The following is a description of a gene set: Human Gene Set: DESCARTES_FETAL_PANCREAS_ACINAR_CELLS The gene expression program underlying the specification of human cell types is of fundamental interest. The study authors generated human cell atlases of gene expression and chromatin accessibility in fetal tissues. For gene expression, the study authors applied three-level combinatorial indexing to >110 samples representing 15 organs, ultimately profiling ~4 million single cells. The study authors leveraged the literature and other atlases to identify and annotate hundreds of cell types and subtypes, both within and across tissues. Our analyses focused on organ-specific specializations of broadly distributed cell types (such as blood, endothelial, and epithelial), sites of fetal erythropoiesis (which notably included the adrenal gland), and integration with mouse developmental atlases (such as conserved specification of blood cells). These data represent a rich resource for the exploration of in vivo human gene expression in diverse tissues and cell types. Marker genes curated from the annotated cluster as represented in the Descartes Human Gene Expression During Development database. species: Homo sapiens from publication Cao J, O'Day DR, Pliner HA, Kingsley PD, Deng M, Daza RM, Zager MA, Aldinger KA, Blecher-Gonen R, Zhang F, Spielmann M, Palis J, Doherty D, Steemers FJ, Glass IA, Trapnell C, Shendure J (PMID 33184181), and this is the list of marker genes: CELA3A, CTRC, CELP, IL17C, CPA2, ENSG00000259203, SERPINI2, MT1M, REG3G, CCKBR, NCCRP1 (NCCRP1, F-box associated domain containing), PRR35, MT2A, MT1H, PRSS1, HTR1E, AKR7A3, CELA3B, FBXO2, RPL7AP63, CCKAR, STEAP1, GSTA1, AQP8, CUZD1, GATM, GP2, IL22RA1, SEL1L, LHB, ABCC6P1, FREM2-AS1, MEP1A, ALB, RTL1, BCL2L15, CEL, CTRB2, SPINK1, REG1A, APOB, PNLIP, PTF1A, MT1HL1, ENSG00000243620, CBS, MIOS-DT, RBPJL, REG4 (NCBI Gene Id 83998), C12orf71, TMED11P, PNLIPRP1, MYMX, PTCHD3 (NCBI Gene Id 374308), AQP12A, SLC16A12, SPX, SLC39A5, KCNE5, CLPS, CLPSL1, KLB, POMC, MT1E (NCBI Gene Id 4493), AKR7L, PRR15, RNF186, FABP1, CPB1, MT1X, ERP27, REG1B, PRSS16, LYPLAL1-AS1, FAM87A, ADAM7-AS2, CTRB1, OPN4, CNPY1, PRSS3P1, DPEP1, PLA2G1B, LINC02477, CPA1, LINC02472, KLK1, AMBP, SYCN, MT1G, CELA2A